Given this list of marker genes KRT6A, KRT6B, SCN9A, LAMA3, TSC1, WNK1, MBTPS2, IFNG, RETREG1, CEBPE, SLC39A4, STING1 (NCBI Gene Id 340061), ADAM17, KIF1A, LAMC2, STAT3, LAMB3, KRT17, TSC2, NFKB2, BLM, KRT16, here is a description of the gene set: Human Gene Set: HP_ABNORMAL_PERIUNGUAL_MORPHOLOGY species: Homo sapiens Abnormal periungual morphology An abnormality of the region around the nails of the fingers or toes.